Given this list of marker genes TOP1MT, TOP3B, TOP1, TOP3A, TOP2B, TOP2A, SPO11, here is a description of the gene set: Human Gene Set: GOMF_DNA_TOPOISOMERASE_ACTIVITY Catalysis of the transient cleavage and passage of individual DNA strands or double helices through one another, resulting a topological transformation in double-stranded DNA. studied in species Homo sapiens